Given this list of marker genes Srsf8, Slc39a5, Puf60, Rest, Rbm4, Exosc10, Rbmy, Fmr1, Lmntd2, Rbm7, Eif1, Srrm4, Ncbp1, Celf1, Snrnp70 (NCBI Gene Id 97422), Malat1, Khdrbs2, Rbm10, Rbmyf3, Snw1, Rbpms2, Khdrbs1, Srsf3, Rbmyf1, Wtap, Dyrk1a, Rbmxl1, Wdr77, C1qbp, Srsf12, Tra2a, Rbmx, Rbm5, Srsf9, Tra2b, Ythdc1, Larp7, Hmx2, Eif4a3, Qki, Ptbp1, Rbmxl2, Rbfox1, Slirp (NCBI Gene Id 69144), Sf1, Nsrp1, Magoh, Khdrbs3, Rbm15, Mettl16, Celf3, Upf3b, Thumpd2, Prdx6b, Srrm1, Zfp64, Srsf4, Prmt5, Celf6, Nup98, Mbnl2, Rbm24, Arb2a, Rbm8a, Smu1, Rbmyf9, Rbm3 (NCBI Gene Id 72067), Upf1, Rnps1, Rbm20, Rbpms, Rbfox2, Rbfox3, Pcbp4, Hnrnpk, Srsf7, Larp7-ps, Upf3a, Srsf10, Hnrnpl, Acin1, Obi1, Ncl, Nova2, Myod1, Gm7324, Hnrnpa2b1, Jmjd6, Srsf6, U2af2 (NCBI Gene Id 22185), Clns1a, Son, Cirbp, Hnrnpu, Rbm47, Tia1, Rbm39, Sap18b, Sap18, Rbm8a2, Thrap3, Srsf2, Rbmyf6, Zbtb7a, Celf4, Celf2 (CUGBP, Elav-like family member 2), Rbm15b (NCBI Gene Id 76348), Hspa8, Ddx5, Dazap1, Rbm25, Celf5, Ptbp3 (polypyrimidine tract binding protein 3), Rbm42, Arglu1, Mbnl1, Akr1c6, Prpf19, Sfswap, Nova1, Npm1, Ddx17, Prdx6, Rbm11, here is a description of the gene set: species: Mus musculus Mouse Gene Set: GOBP_REGULATION_OF_MRNA_SPLICING_VIA_SPLICEOSOME Any process that modulates the frequency, rate or extent of mRNA splicing via a spliceosomal mechanism.